The following is a description of a gene set: The chemical reactions and pathways resulting in the breakdown of any one of a family of organic molecules consisting of a purine or pyrimidine base covalently bonded to a sugar deoxyribose (a deoxyribonucleoside). Mouse Gene Set: GOBP_DEOXYRIBONUCLEOSIDE_CATABOLIC_PROCESS species: Mus musculus, and this is the list of marker genes: Dera, Xdh, Ada, Urah, Urad, Gda, Dpyd, Pnp, Uox